Given this list of marker genes ASCL2, SPNS2, RIPOR2, CCL2 (C-C motif chemokine ligand 2), CCL20, ADAM8, AKT1, ADAM17, P4HB, GPR15LG, FADD, XCL1, ABL1, CXCL13, MADCAM1, ITGA4, ECM1, CXCL10, CD69, SPN, RHOA, CXCL12 (C-X-C motif chemokine ligand 12), KLRK1, CCL5, OXSR1 (oxidative stress responsive kinase 1), AIF1 (NCBI Gene Id 9471), CCL3, SLC8B1, CRKL, TNFSF14, WNT5A, STK10, KLRC4-KLRK1, CD200, PTK2B, WASL, PYCARD, CRK, ADTRP, DOCK8, IL27RA, LGALS9, TMEM102, CCL4, JAM2, CD200R1, TNFRSF14, LRCH1, ITGB3, CORO1A, RIPK3, AIRE, NEDD9, CCR2, PADI2, MIA3, APP, GCSAML, MED23, CCL7, ADAM10, SELENOK, GCSAM, S100A7, STK39 (serine/threonine kinase 39), CCR6, CD99L2, WNK1, CCL21, MSN, APOD, ABL2 (NCBI Gene Id 27), here is a description of the gene set: Human Gene Set: GOBP_REGULATION_OF_LYMPHOCYTE_MIGRATION species: Homo sapiens Any process that modulates the frequency, rate or extent of lymphocyte migration.